Given this list of marker genes ALDOB, PGAM1, LDHAL6B, BPGM, PGAM4, LDHA, ALDOC, ENO3, PGAM2, ENO2, GAPDH (NCBI Gene Id 2597), PFKL, PKM, ENO1, GPI, LDHAL6A, PGK2, ENO4, LDHC, PGK1, PFKM, PFKP, LDHB, ALDOA, PKLR, here is a description of the gene set: Pathway Definition from KEGG: Glc-6P -- GPI >> PFK >> ALDO >> GAPDH >> PGK1/2 >> (PGAM,BPGM) >> ENO1/2/3/4 >> (PKLR,PKM) >> (LDH,LDHAL6) -> Lactate Glycolysis. Pathway ID: N00731. Pathway type: Reference. Pathway class: nt06017 Glycogen metabolism. Human Gene Set: KEGG_MEDICUS_REFERENCE_GLYCOLYSIS species: Homo sapiens